The following is a description of a gene set: Human Gene Set: GSE4984_GALECTIN1_VS_VEHICLE_CTRL_TREATED_DC_UP from publication Fulcher JA, Hashimi ST, Levroney EL, Pang M, Gurney KB, Baum LG, Lee B (PMID 16785517) Genes up-regulated in monocyte-derived dendritic cells: LGALS1 versus vehicle. studied in species Homo sapiens Human monocyte derived dendritic cells matured via galectin-1 or LPS., and this is the list of marker genes: MCEMP1, ZBTB33, FXYD5, USP43, KIAA1143, ZNF548, LINC02591, LANCL1, KLC4, ZNF500, FHIT, ARGLU1, DDB2 (NCBI Gene Id 1643), ZMYM1, JAKMIP2, XYLT2 (xylosyltransferase 2), SUN2 (Sad1 and UNC84 domain containing 2), CLCN6, STK4, PATL2, PAM, ZNF821, PARP15, LMF1, FRMD3, KANK3, ATG14, SCAF11, TXK, CAMLG, GNPTG, RNF169, KIZ, ARIH2, DLG3, CDKN1C, TSC1, ATP2B4, IDO2, CUTA, FSIP1, MOV10, MROH1, PDZK1, SMAD2, NTNG2, GNAL, TPK1, ATM, PTBP2, IFT20, LRCH4, MIGA2, TMEM91, RCBTB1, APPL2, FGD3, TXNDC12, S1PR4, ACBD5, ETAA1, PYCARD, TADA3, ARB2A, PARP16, SURF1, EIF2AK4, AGO1, TCHP, HHEX, ACKR3, BCL9L, CD244, FOXK1, TRAV8-3, ABRAXAS1, ZNF212, CD37, MAGEE1, THAP8, CTBP2, TESK2, EIF4B, EAPP, SMAD5 (NCBI Gene Id 4090), SLC6A12 (NCBI Gene Id 6539), TMPRSS13, ADCY7, CDK19, TMEM42 (transmembrane protein 42), SCAMP1-AS1, ARHGEF6, LTK, USP24, DNASE1, TK2, VPS16, PLK2, UPF3A, LINC01588, CYTH3, DENND2D, ASPRV1, GP5, CARINH, ITPKB, TMEM107, ZSCAN16-AS1, SCAMP1, NBPF10, LINC00964, KANSL2, DIAPH1, YPEL5, WDR72, ZNF558, EID1, ABCD1, TARS3, KDM2B (NCBI Gene Id 84678), ZFAND2A, ABCA2, STX16 (syntaxin 16), PAIP2B, CCR10 (NCBI Gene Id 51565), SLC24A1, TMEM59, MRFAP1L2, ALAD, ARHGAP4, CBX3P2, DHRS13, WASL, PIKFYVE, DOK2, IGSF6, ACRBP, ZMYND11, TMEM170B, P2RY10, CATSPERE, VCPIP1, GTF3C1, EXTL2, UBQLNL, ALOX15, LYPD3, LAMA2, METRNL (meteorin like, glial cell differentiation regulator), EXD3, RGL2, LRIG2, TRIM41, TP53INP1, TMF1, ZNF398, C17orf67, SERPINA2, PATZ1, SMIM14, RHOC, RBSN, KCNH3, SYK, WBP1L, CTPS2, DGKQ, ALDH3B1, SH3TC1, ZBTB40, CTSK, SNPH, BRD3, C2orf49, CARD16, HCG4B, ZC3H6, MIR646HG, LIPT1, CEP85L, RPRD1A, FAM53B, SIDT1, FOXO4, TANC2, CLK3, PDLIM2, INPP5F, SUCLG2, SGSM3, FCHSD1, REC8, SIRT5 (sirtuin 5)